Given this list of marker genes CD40, SPATA13, ARHGAP30, LGALS3BP, ALS2, TAPBP, AIF1L, F11R, VGLL4, COA5, NT5C3A, FCER1G, UNC93B1, IFT25, ADPRM, SOCS1, PTK2, ZNF513, OCEL1, SERPINB9, PDE1B, CFAP410, C19orf53 (NCBI Gene Id 28974), GCH1, ITM2B, BEND6, CASP7, RSAD2, DNAL1, MAF, TLR4, GMPPB, PARP12, RIN1, CSF1, TOR3A, OAS1, RAB19, NACC2, BBS4, IL12RB1, SGCB, TTYH3, PLXNA3, IRGM, SPACA1, IL12A, CUEDC1, MPEG1, ARHGAP8, PLAC8, NDUFA7, BCL9L, PSMB8, NQO2, HLA-C, NAGA, DENND2B (NCBI Gene Id 6764), CASS4, CLCN1, DTX3L, FECH, SH3BP2, BCL2L14, IDNK, WLS, MZT2B, BATF2, SLFN12L, SCLY, FRMD4A, RERE, LGALS9B, SQOR, ACOT8, PSMB9, LLGL1, ZCCHC18, DOCK8, HK1, NBAS, GDI1, MED15, SIN3B, LYN (NCBI Gene Id 4067), PCBD1, CLEC6A, CCRL2, PLSCR3, GSAP, DOK1, B4GALT1, AOPEP, GZMB, PARP11, SOAT2, ZNF691, ITPR1, KIF13B, CD86, ARL4C, IFNG, RIGI, TALDO1 (NCBI Gene Id 6888), CSF2, UBALD2, ATOX1, CCDC12, IFITM3, NKG7, IRF7, CTSK, TRAFD1, TRAF5, CFAP36, ADIPOQ, SESTD1, TFEC, TRIM5, CES5A, PDLIM4 (PDZ and LIM domain 4), CCND3, PDE8A, MYCBP2, TMBIM6, NOD1, FXN, TSGA10, ENG, IFIT1, C1orf54, ENPP4, TMEM87A, MIDN, DAPP1 (NCBI Gene Id 27071), OAS3, TP53BP1, SERPINB6, ALOX5AP, QNG1, GSDMD, ZBP1, UMODL1, ADGRL2, NSG2, LYST, PARP8, TMEM140, SIAE, DHRS7, GBP2, IKZF2, GSN, PARP14, ATP8A1, IL2RB, MCEMP1, TMEM106A, D2HGDH, DAAM1, NIT1, TAPBPL, CDC42EP2, ZNF449, GBP4, TBX21, IP6K1, AGR2, ADORA2A, STMP1, EPSTI1, ZNFX1, CFAP126, TMEM219, ADAMTS6, ISG20, ZNF23, STAT1, FAM221A, FAM209A, IRF1, OAS2, GPR18, PAGR1, CA2, DENR, HLA-B, C3orf80, ZFYVE26, LAMTOR4, IFT80, P3H1, UHRF1, SUCO, C19orf12, XDH, RGS12, RBM43, BAK1, GCHFR, here is a description of the gene set: from publication Doering TA, Crawford A, Angelosanto JM, Paley MA, Ziegler CG, Wherry EJ (PMID 23159438) Human Gene Set: GSE41867_DAY6_EFFECTOR_VS_DAY30_EXHAUSTED_CD8_TCELL_LCMV_CLONE13_UP studied in species Homo sapiens During acute viral infections, naïve CD8+ T cells differentiate into effector CD8+ T cells and, after viral control, into memory CD8+ T cells. Memory CD8+ T cells are highly functional, proliferate rapidly upon reinfection and persist long-term without antigen. In contrast, during chronic infections, CD8+ T cells become “exhausted” and have poor effector function, express multiple inhibitory receptors, possess low proliferative capacity, and cannot persist without antigen. To compare the development of functional memory T cells with poorly functional exhausted T cells, we generated longitudinal transcriptional profiles for each. Genes up-regulated in CD8 T cells during chronic infection with LCMV-Clone 13: effectors at day 6 versus exhausted at day 30.